The following is a description of a gene set: studied in species Homo sapiens Interleukin-1 processing Human Gene Set: REACTOME_INTERLEUKIN_1_PROCESSING, and this is the list of marker genes: GSDMD, IL1A, NFKB1, CASP1, IL1B, RELA, CTSG, NFKB2, IL18